The following is a description of a gene set: Insulin signaling species: Homo sapiens Human Gene Set: WP_INSULIN_SIGNALING, and this is the list of marker genes: EHD1, FLOT2, ARF6, MAP2K1, INPP4A, IRS1, PIK3C2A, PIK3CB, SOCS3, ARHGAP33, CBLC, JUN, CYTH3, MAP3K11, SH2B2, MAP2K3, GRB2, MAP4K5, IKBKB, MAP3K10, PIK3CG, PIK3CD, RAPGEF1, SHC1, PRKCD, MAPK12, PRKAA2, PTPN11, XBP1, RPS6KB2, SOS2, MAP2K4, PRKCZ, MAP3K5, MAP3K4, PIK3C2G, LIPE, MAPK6, MAP3K12, RAC1, MAP3K3, GSK3B, REG1A, RAF1, RPS6KA1, TRIB3, MAP3K13, PRKCQ, PRKCB, PRKAA1, EIF4E, MAP2K2, MAP4K1, TSC2, MAP2K7, AKT2, MAPK1, RPS6KA4, KIF5B, MAP3K7, GAB1, SLC2A4, MTOR, SHC2, RPS6KA3 (NCBI Gene Id 6197), HRAS, MAPK13, SLC2A1, SGK2, RPS6KA2, PDPK1, MAPK11, FOS, PFKM, STXBP1, INPPL1, SRF, SORBS1, PTPN1, MAP3K9, GRB10, MAPK9, PRKCA (NCBI Gene Id 5578), PIK3R4 (phosphoinositide-3-kinase regulatory subunit 4), SNAP25, SOS1, EGR1, VAMP2, SNAP23, PIK3CA, PFKL, PIK3C3, SOCS1, MAPK4, PTEN, EIF4EBP1, EHD2, TBC1D4, IRS2, SGK3, PIK3R1, ELK1, MAPK3, IRS4, GRB14, GYS2, FOXO1, STXBP2, CAP1, MAP3K8, MAP3K6, RHEB, RRAD, GYG1, STXBP3, MAP2K5, MAP4K2, ARF1, PRKCI, MAP3K1, GSK3A, CBLB, MAP4K3, INSR, FLOT1, GYS1, IGF1R, PTPRF, KIF3A, MAPK14, TSC1, MAP3K14, RHOQ, PIK3R2, PPP1R3A, RPS6KA6, RHOJ, MAP4K4, PIK3R3, STXBP4, CBL, SHC3, AKT1, RAC2, RPS6KB1, MYO1C (myosin IC), RPS6KA5, MAPK10, SGK1, MAP2K6, PRKCH, MAPK8, MAPK7, CRK, STX4, FOXO3, RAB4A, MAP3K2, MINK1, ENPP1 (NCBI Gene Id 5167)